Given this list of marker genes CTNNA1, SUFU, MDFIC, YWHAB, ILRUN, POLR1A, NFKBIA, APOD, TMEM98, DCLK2 (doublecortin like kinase 2), LZTS2, FBXO4, LATS2, CD36, RAB23, GSK3B, MAGED1, PKIA, ANGPT1, SIN3A, EI24, SUMO1, CHP1, CLDN18 (claudin 18), PKIG, MARK3, SIRT6, LILRB4, LATS1, FERMT1, TRIM40, MTOR, CABP1, OTUD7B, APP, TRIM29, NF1, MFHAS1, UFM1, YWHAZ, here is a description of the gene set: studied in species Homo sapiens Any process that stops, prevents or reduces the frequency, rate or extent of protein localization to nucleus. Human Gene Set: GOBP_NEGATIVE_REGULATION_OF_PROTEIN_LOCALIZATION_TO_NUCLEUS